Given this list of marker genes XXYLT1, RXYLT1, POGLUT2, XYLT1, GXYLT2, POGLUT3, POGLUT1, LARGE2, LARGE1, GXYLT1, XYLT2, here is a description of the gene set: species: Homo sapiens Human Gene Set: GOMF_UDP_XYLOSYLTRANSFERASE_ACTIVITY Catalysis of the transfer of a xylosyl group from UDP-xylose to an acceptor molecule.